The following is a description of a gene set: studied in species Homo sapiens The process in which the anatomical structures of the digestive tract are generated and organized during embryonic development. The digestive tract is the anatomical structure through which food passes and is processed. Human Gene Set: GOBP_EMBRYONIC_DIGESTIVE_TRACT_MORPHOGENESIS, and this is the list of marker genes: IHH, SIX2, NIPBL, PDGFRA, FGFR2, SHH, FGF10, PITX2, HNF1B, HLX, TCF21, OVOL2, FOXF1, SOX11, RBPMS2, GLI3, ID2, SHOX2